Given this list of marker genes KCNJ4, NKX3-1, NCOA4, PDE5A, DDHD2, BRWD3, RGS4, PCDHA13, MAP2, MIP, IPMK, TNFRSF19, SFRP2, NDFIP2, KRTAP2-4, UVSSA, DICER1, C14orf132, DOCK8-AS1, CBX6, ZNF598, PRKAR2B, ELOVL5, JAKMIP1, ZBTB41, CYLD, FRZB, SPRED1, MAFG, LONRF3, SOCS6 (suppressor of cytokine signaling 6), GAREM1 (NCBI Gene Id 64762), PLCB1, PAK6-AS1, CNOT4, SPTSSB, WBP4 (NCBI Gene Id 11193), KATNAL1, PCDHA8, TSHZ3, PDCD10, INSIG1, SETDB2, MAEA, MID1, DSG1, LSM12, SACS, GNAI3, AS3MT, FRA10AC1, RARG, AEBP2, PIGK (NCBI Gene Id 10026), GLS, SF3B3, USP33, PLEKHA1, ARMC1, CAMK2G, ANKRD46, IL33, DIAPH1, CPEB3 (NCBI Gene Id 22849), KBTBD11, FZD6, SYT11, POU3F4, PRPF39, GLIS3, CNKSR2, STRN, MAMDC2, SPATA6L, FAM76B, SMCR8, PCDHA4 (NCBI Gene Id 56144), VPS35, PCDHA10, LINC02693, TSC1, EPC2, GPATCH2L, FGD6, RIMS2, PCDHA7, MAP7, CACNA1C, FNDC3B, NEUROD2, SAP30L, ATP2A2, STXBP5, SRBD1, MEF2A, SCN3A, USP19, LONRF1, MYL12A, NAV2, OLFM3, ATP11A, MGAT2, PPP1R15B, CLINT1, HOXA1, HECW2, CCAR1, ANO4 (anoctamin 4), CNTN1, GPC3, FBXO8, SENP2, SMAD4, MED12L, NUP107, DNA2, ZC3H7A, CDC42BPA, ELOC, RBAK, MFHAS1, ABI1, RHOBTB3, TMEM250, DCUN1D4, XYLT1, TENT2, GALNT4 (polypeptide N-acetylgalactosaminyltransferase 4), AFTPH, PCDHA3, TP63, ABHD17B, F3, SNX27, SGCB, PPP1R3D, RBM11, TAOK1, NLGN4Y, PRSS23, ATRN, GABRB2, ARHGEF7, SENP1, SMAD5, PIGM, SRSF12, LNPEP, ITM2C, RAB23, FAM217A, TCF4, KCNE3, CSMD1, BMP3, PCDHA9, WDR45B, USF3, TPGS2, MAPRE2, PCSK5, ST8SIA3, SOX11, TNPO1, PRKAA1 (NCBI Gene Id 5562), KPNA6, TRIO, GSPT1, ZBTB18, TMEM9B, PUM1, GCC2, TMEM68, HIPK3, SOX6, INO80D, PIK3R3, MAP3K20, SDC1, PPP3R1, GABRA5, NEDD4L (NCBI Gene Id 93998), GPM6A, PIP5K1B, PPM1B, PLXNA4, SPTLC2, CBR4, SIM2, FAR1 (fatty acyl-CoA reductase 1), PAK5, SLC12A8, TMEM98, DNAJC16, DPP10, CFL2, MSRB3, CDC27, PTPRR, DDX39B, MSL2, ABCB10, UHRF2, LRP8, HMGA2, ATP11B, RAB21, LRP6, ARL6IP1, PCDHA12, CCAR2, UNC5C, CLIP4, PCDHA11, MED13L, GABRA4 (gamma-aminobutyric acid type A receptor subunit alpha4), CLOCK, SPART, TGFBR1, SALL1, EPB41L4A, KBTBD8, MATN3, KIAA0586, CPS1, CABLES2, SLC16A7, SELENOT, KCTD8, ZNF367, KLHL8, JCAD, PWWP3B, RAB9B, FOXN3, PCDHA2, TRAPPC10, SERBP1, B3GNT2, MDM4, MTF1, TRIM33 (tripartite motif containing 33), TENM1, HSBP1, PRDM16, GTF2A1, UTS2, MEGF10 (NCBI Gene Id 84466), ZNF92, PCDHAC1, NRXN1, PDS5A, MIER1, CALHM4, C11orf96, USP4, BPTF, PCDHA5, CREBRF, CLIP1, GPR85, SPON1, NPTN, CAMSAP1, ARPC3, TMEM14B, ADAMTS15, ATG14, CCNL1, DLG2, MMP16, SHANK1, WDR44, CGGBP1, DPY30, RICTOR, MAPK8, FZD3, CDK19, SLITRK5, SORBS1, SVOP (SV2 related protein), KDM7A, NGLY1, KDM2B, IVNS1ABP, TGM3, SECISBP2L, PALD1, PPTC7, LRRFIP1, CERT1, ZMAT3, MEF2C, KCNJ13, STAU2, CACUL1, S1PR1, CREB1, MMGT1, SLC30A4, PCDHA1, FSTL1, CTNNB1, ROBO1, USP25, TDRP, CPSF6, HOXC10, DOCK9, SLC2A13, YES1, SLC30A5 (solute carrier family 30 member 5), SMURF2, UCP3, GIT2, CCR2, SUPT7L, PPP1R3B, ZC3HAV1L, SMU1, RPL26L1, MEOX2, C2orf42, PROX1, TMEM255A, UBA3, EZH2, RBMS2, PSAP, BNC2, FAM117A, PAX9 (NCBI Gene Id 5083), CAMK2B, FAM168B, NANP, TRIM67, CPNE4, ACADL, ADGRA2, KLF7, PLAC8, GID4, ECT2, SYNM, CDC20B, FAM43A, CBFB, CHMP2B, PCDHAC2, IGF2BP2, RFX7 (NCBI Gene Id 64864), CDCA7L, SORCS1, SEPTIN11, KLHL15, RSPO3 (R-spondin 3), SEH1L, RBMS1, RBM27, MPRIP, GUCD1, SCAF11, PPP2R5E, NADK, PEX5L, ANKRD44, PHLDB2, LRRC8B, ARPP19 (cAMP regulated phosphoprotein 19), SLC38A1, THOC3, ST3GAL2, ELAVL4, ADNP, NHEJ1, ALPI, CD47, LRP2, CAND1, KCNJ3, TGIF2, LYPLA1, MAN1A1, RC3H1, EPS15, PRMT8, PSD3, POC1B-GALNT4, VKORC1L1, SULT1E1, TXNL1, KRT24, PCCB, TMTC1, RASGRP4 (NCBI Gene Id 115727), GNPNAT1, SLC4A7, STXBP6, ESR1, BMPR2, IDS, TGFBR2, SNIP1, PCGF5, GDAP2, FBXO9, HNRNPR, ACSL6 (acyl-CoA synthetase long chain family member 6), MKX, DENND4C, C15orf61, BTBD7, WNK3, SH3KBP1, TLCD4-RWDD3, GRM7, ORMDL3, PFDN4, PIK3CA, MBL2, THSD7A, TENT4B, FLNC, ERF, IGFBP3, ELAVL1, ACVR2A, LCOR (NCBI Gene Id 93376), KLF10, MEAK7, RHAG, RUNX1T1, BBOX1, TRA2B, CASP10, YAP1, EGR4, INPP5J, API5, ATP6V1B2, MTMR6, TAOK3, CNTFR, TMCC3 (NCBI Gene Id 57458), EIF2D, MAP2K3, CNTNAP3B, SGPP1, HOXA9, SLC6A6, KMT2E, SPTY2D1, ENTHD1, ASB5, ZNF217, L3MBTL3, MAT2B, LCLAT1, ZC3H4, BNIP2, GPBP1L1, ATAD2B, ZNF708, FOXJ2, MYBL1, PCDHA6, MC2R, ELOVL6, YTHDF3, ZEB2 (NCBI Gene Id 9839), ABLIM1, AGPAT5, GALNT16, NEDD1, PGM3 (NCBI Gene Id 5238), HCFC2, NUP58, C1QTNF2, SEMA4C, RNF19A (NCBI Gene Id 81036), ACYP2, SDC2, CHFR, here is a description of the gene set: from publication Chen Y, Wang X (PMID 31504780) Genes predicted to be targets of miRBase v22 microRNA hsa-miR-548aj-5p, hsa-miR-548g-5p, hsa-miR-548x-5p in miRDB v6.0 with MirTarget v4 prediction scores > 80 (high confidence targets). species: Homo sapiens Human Gene Set: MIR548AJ_5P_MIR548G_5P_MIR548X_5P